Given this list of marker genes Klhl1, Scn1a, Cacnb4, Cln8, Uchl3, Chd7, Idua, Dab1, Dmrt3, Cacna1c, Npc1, Trh, Hipk2, Efnb3, Htra2, Uchl1, Arrb2, Scn8a, Mapt, Enpp1, Pmp22, Hexa, Ndufs4, Axin1, Ctns, Abhd12, Drd1, Zic1, Fxn, Gbx1, Glra1, Agtpbp1 (NCBI Gene Id 76578), Chat, Abl2, Zmpste24, Drd2, Atg7, Cntn2, Rnf170, Epha4, Kcnj10, Cacna1a, Ulk4 (NCBI Gene Id 74372), Fkrp, Sptbn4, Pcdh15, Glrb, Cend1, Oxr1, Kcnma1, here is a description of the gene set: species: Mus musculus Mouse Gene Set: GOBP_ADULT_WALKING_BEHAVIOR The behavior of an adult relating to the progression of that organism along the ground by the process of lifting and setting down each leg.